Given this list of marker genes SRSF3, FKBP6, TDRKH, TERT, TUT4, TEX15, GPAT2, MOV10L1 (Mov10 like RNA helicase 1), TDRD7 (NCBI Gene Id 23424), PARN, IL6, PLD6, DROSHA, TSN (translin), TP53, DDX4, HOXB-AS3, HNRNPA2B1, DDX5, PIWIL2, AGO2, PRKRA, SMAD2, ZC3H7A, FBXO24, ZC3H7B, TSNAX, TARBP2, ZMPSTE24, METTL3, LIN28A, TDRD1, SMAD1, ADAR, PUS10, PIWIL1, PUM2, DGCR8, DICER1, SMAD3, NCBP2 (NCBI Gene Id 22916), AGO1 (NCBI Gene Id 26523), SRRT, HENMT1 (NCBI Gene Id 113802), NUP155, TDRD9, PNLDC1, TUT7, BMP4, LIN28B, PIWIL3, BCDIN3D, TRIM71, MAEL, SNIP1, TDRD12, NCBP1, AGO3, TDRD6, TRUB1, RIPK1, PUM1, STAT3, PIWIL4, EXD1, TGFB1, SPOUT1, GTSF1, ZC3H10, AGO4, here is a description of the gene set: A process leading to the generation of a functional regulatory non-coding RNA. Human Gene Set: GOBP_REGULATORY_NCRNA_PROCESSING studied in species Homo sapiens